Given this list of marker genes ADA, CD40LG, EPHB4, PTPRC, SP110, CD40, here is a description of the gene set: studied in species Homo sapiens Absence of lymph node germinal center Absence of germinal centers in lymph nodes. Germinal centers are the parts of lymph nodes in which B lymphocytes proliferate, differentiate, mutate through somatic hypermutation and class switch during antibody responses. Human Gene Set: HP_ABSENCE_OF_LYMPH_NODE_GERMINAL_CENTER